The following is a description of a gene set: Any DNA replication initiation that is involved in cell cycle DNA replication. Human Gene Set: GOBP_CELL_CYCLE_DNA_REPLICATION_INITIATION studied in species Homo sapiens, and this is the list of marker genes: MCM2, POLA1, MCM3, MCM4, GINS3